Given this list of marker genes Fbll1, Trmt2b, Zcchc4, Mrm1, Nop2, Mettl5, Tfb2m, Trmt112, Dimt1, Nsun5, Mettl16, Mettl15, Mrm2, Tfb1m, Emg1, Mrm3, Ftsj3, Nsun3 (NOL1/NOP2/Sun domain family member 3), Nsun4, Fbl, Fdxacb1, Bud23, here is a description of the gene set: The posttranscriptional addition of methyl groups to specific residues in an rRNA molecule. Mouse Gene Set: GOBP_RRNA_METHYLATION species: Mus musculus